Given this list of marker genes Slc22a5, Slc22a16, Slc22a1, Slc22a3, Slc22a15 (solute carrier family 22 (organic anion/cation transporter), member 15), Slc22a2, Slc22a4, Slc22a18, here is a description of the gene set: Mouse Gene Set: REACTOME_ORGANIC_CATION_TRANSPORT Organic cation transport studied in species Mus musculus